Given this list of marker genes SKP2, VAPA, PRUNE2, SOCS3, PHLDB2, ETNK1, CACUL1, FOXF1, ENC1, PGS1, NKAIN1, COX11, MSH3, NUP205, UGCG, CAP1, ATP8B4, RFC3, TNS3, IRX1, DICER1, KCNS3, SELENON, C5orf15, GTF3A, FSCN1, NRP2, SERP1, ZNF644, AGPAT5, LAMB3, MET, ACTG1, C10orf71, SETBP1, CDK14, KBTBD8, HNRNPA3, TCF7L1, ARPC2, IFT81, RUNX1, PBX1, EXT2, PPP1R3B, WDR11, CA11, FAT1, ARID1A, NHP2, MEDAG, ATP1A3, SFXN1, SDC1, PODXL, STC1, SDC3, MAGED2, HSPA4, SOD1, PTPN12, OAT, DOCK10, GPHN, DEAF1 (NCBI Gene Id 105376508), ARHGEF3, VDAC1, ARHGEF10, ZNF420, GXYLT2, CD81, MEIS1, COL4A1, PACS1, NR2F2, TBC1D2B, SF3B5, CEBPZ, CCNC, SLC7A2, MEST, MAP4K4, DNAJC10, EPHB2, COPS8, FOXK1, GALNT2, NAA20, EXOSC2, AOPEP, ZMIZ1 (zinc finger MIZ-type containing 1), ARHGAP26, ZIM2, JPT2, MCC, CCND2 (cyclin D2), ACVR1, ZNF331, VIPR2, GNAZ, SMPDL3A, ALK, SLC46A3, COX16, NXT1, ZW10, STX8, NLGN1, RRP1B, LMNB1, TLE5, TRAM2, DAAM1, SPICE1, DPYSL3, PLCE1, ZNF664, ZDHHC21, PPP4R2, PAFAH1B3 (platelet activating factor acetylhydrolase 1b catalytic subunit 3), VRK1 (NCBI Gene Id 7443), LOXL2, FAM81A, ATRN, DAPK1, C3orf70, THAP1, CLINT1, ZC3H13, TEX10 (NCBI Gene Id 54881), PRDM12, STK24, SDC2, PCCB, SUMF1, NRG1, KHDRBS3, RBBP8, SLC25A26, EYA1, FAM151B, GNB5, TFAP2B, GAS1, RHOQ, SYTL3, RNF145, ASS1, SIPA1L1, NOTCH2, TMEM165, RGS17, PALD1, RGPD4, ANKRD13A, CASK, MSI2, CAPRIN1, ZNF217, MTPAP, CAND1, ADAMTS15, DUSP6, HS1BP3, PROX1, JAKMIP2, APBB2, CDON, M6PR (NCBI Gene Id 4074), SLC38A1, PFN2, ASB7, PCBD1, KLF9, GLRX5, ZNF77, GOLGA7, MYCN, ERRFI1, ACTR3C, CABLES1, HSBP1, TBX15, ANLN, FHIP2A, SMARCA2, ADAMTS14, RAPGEF1, NAPG, GPR107, SBF2, SLC38A9, THEMIS2, CHST8, DYRK2, PRKAR1A, NOG, RGMA, FAM199X, SPOCK3, PRMT3, CHSY1, KCNMB4, AUTS2, BMERB1, SMARCB1, BCHE, RIMKLB (ribosomal modification protein rimK like family member B), ST6GALNAC3, SEMA6A, ATF3, GIT2, LDLRAD3, SNX9, APP, NAV2, CPA5, TRAP1, QKI, DLG5, EXTL3, BABAM1 (BRISC and BRCA1 A complex member 1, NCBI Gene Id 29086), SDK1 (NCBI Gene Id 221935), CRPPA, CSRNP2, RNF11, PGRMC2, SRSF6, PSIP1, POMT2, RNF216 (ring finger protein 216), ITPKB, HS6ST2, DIS3L, TNFAIP3, PARP4, ARHGAP12, LRRC10B, PPM1H, VANGL2, ETV5, SRD5A3, MOCS2, SF3A3, MFSD2A, NFYA, NAV1, LRRFIP2 (LRR binding FLII interacting protein 2), IL17RD, TSC22D2, TENM3, N4BP3 (NEDD4 binding protein 3), MYH9, WARS1, FGGY, ERGIC1, CDH4, JARID2, LRIG3, PEG10, HNRNPK, ZNF483, CDC123, SATB2, SSU72, CSRP1 (NCBI Gene Id 1465), NELL1, WSCD1, CGRRF1, UBE2J1, DHX32, PKP1, WNK1, ZNF804A, MSH6, EYA2, NOLC1, FAM217B, BBIP1, RPL23A, REPIN1, PTCD2, ZNF264, POLR1D, LMO4 (LIM domain only 4), CTDSP2, ERLIN2, RRP15, PEG3, UBL7, RRAGA, ELAPOR2, UBE2E2, TSPAN9, KCNN3, SGMS1, GALNT17 (polypeptide N-acetylgalactosaminyltransferase 17), CNOT2, YWHAZ, KIF5B, HELB, TNFRSF21, ZDHHC6, GNG12, PAX3 (NCBI Gene Id 5077), VIM, THSD4, PTTG1IP, RBPJ, ELMO1, ACTB, NR3C1, STAT3, KIAA1614, BTD, FUT10, PCSK6, FGF8, CYRIA, FAM89A, DTD1, BCOR, ARL4C, TCF20, RCN1, MIPEP, NPM3, PNO1, PGF, SIK1, SPATS2L, HACL1 (NCBI Gene Id 26061), GART, UBE2G1, CELF2, SLC38A10, LIMCH1, SFMBT2, TMBIM4, COL4A2, ACSL3, CEBPG, PON2, ETAA1, TBCD, TUT7, GADD45A, RNGTT, FBXO7, LEPROTL1, DNM3, FGFR2, SEL1L3, STX11, SCARB1, SULF2, PIPOX, MDH2, PPCDC, PKN2, PITX2, AP1B1, ATP2A2, GLO1, PARP1, NFE2L2, WDFY3, BFAR, TMEM177 (NCBI Gene Id 80775), EFNA5, RAPH1, TNFRSF10B, ARL8B, BCL2, ITGB8, FBXO21, MEIS2, USP1 (ubiquitin specific peptidase 1), IL4R, SLC16A10, PDHB, PLCG1, PIGC, MIF, METTL13, SERPINE2, SPIN2B, CCDC3, ZNF568, XRN1, ABRACL, STMP1, TRIQK, PXDN, KANK4, MAN1C1, EID1 (NCBI Gene Id 27110), MN1, SPATS2, C1GALT1, SHC1, FCRLA, NOS1, CD9, ALDH1A3, PARM1, PID1, SENP2, VTI1A, MDFI, DMRT2, BCL11A, HUNK, TPST1, TSHZ3, POLE3, BMP5, ZNF57, HSPH1, NRN1, MAPK8, MAF, ADAM10, ZXDB, PRKG1, SH3BGR, CHST15, SORCS1, KRCC1, MACROH2A1, MIOS, ASCC3, APPL1, ANK2, FANCF (FA complementation group F), DCTD, DBT, EFHD2, here is a description of the gene set: We identified high-confidence PAX3-FOXO1 target genes by a series of criteria: first, using only PAX3-FOXO1 bound to enhancers recurrent in cell lines and tumors. Secondly, we only selected expressed genes, as PAX3-FOXO1 was not found in repressive chromatin. Third, we excluded nearby expressed genes if they were not found within the same topologically associated domain (TAD) as the PAX3-FOXO1 bound enhancer. Fourth, we also called out the maximally expressed gene within each TAD harboring PAX3-FOXO1. This approach removed 435 nearby but not expressed genes, and 78 expressed but out of TAD bounds. We found 1010 high-confidence targets, 678 of which were novel, and 439 were significantly reduced by shRNA knockdown of PAX3-FOXO1 for 48 hours. The reduced genes are represented in this gene set, which is a subset of GRYDER_PAX3FOXO1_ENHANCERS_IN_TADS. from publication Gryder BE, Yohe ME, Chou HC, Zhang X, Marques J, Wachtel M, Schaefer B, Sen N, Song Y, Gualtieri A, Pomella S, Rota R, Cleveland A, Wen X, Sindiri S, Wei JS, Barr FG, Das S, Andresson T, Guha R, Lal-Nag M, Ferrer M, Shern JF, Zhao K, Thomas CJ, Khan J (PMID 28446439) Expressed genes (FPKM>1) associated with high-confidence PAX3-FOXO1 sites with enhancers in primary tumors and cell lines, restricted to those within topological domain boundaries, which are downregulated by delta log2(FPKM) < -0.2 Human Gene Set: GRYDER_PAX3FOXO1_ENHANCERS_KO_DOWN studied in species Homo sapiens